Given this list of marker genes UBA7, LRR1, ITIH5, PHB1, SELENOS, RIDA, C11orf58, ITPR2, CTRL, XRN1, EML3, TIMM8B, PARD3 (par-3 family cell polarity regulator), SSBP1, ACAD9, PRPF8, LIPT1, PLXNC1, PRPF40A, USP47, PDE8A, SYNGR2, NAA20, EZH1 (enhancer of zeste 1 polycomb repressive complex 2 subunit), TMEM70, TM9SF4, TMBIM4, COMTD1, MYC, DGLUCY, AGT, IFT27, HIBADH, BSPRY, MED12, TIMM44, CYBA, NFKB2, SPDEF, QPCT, EIF1AX, ADAMTS10, PAWR, TARS2, GRIA3, MRPL45, MED28, NUCKS1, DBT, EPCAM, ST3GAL1, NCAPG2, ZNF202, PALS2, PSMB4, SLC29A3, ARL16, GOLGA4, MAD2L1, TDP2, FAIM, FAM81A, VTA1, TOPBP1, IGF2BP3, M6PR, GYPC, ETFB, USP18 (NCBI Gene Id 11274), RPP25, TBL1X, FBXW9, MAPRE2, ZEB2, ACP6, CEBPZOS, MLLT3, RIPK4, RABL6, REL, MRPS11 (NCBI Gene Id 64963), TWIST1, SEC16B, GSAP, TRAPPC12, PARN, NOL7, BTG1 (NCBI Gene Id 694), CPA2, INTS6, LYSMD2, IDH3A, ACSL5, PTEN, DDX39B, MRPL16, IRAK1, THAP4, MTHFS, NUFIP1, ERAL1 (Era like 12S mitochondrial rRNA chaperone 1), CD27-AS1, FNBP4, EXTL3, UNK, HEATR1, RBCK1, APOOL, MMUT, TM4SF5, SRPK2, NNT, SMC3, DGKE, MLST8, SLFN13, SH3GL3, PTCD2 (pentatricopeptide repeat domain 2), VPS53, ARF3, RNF123 (ring finger protein 123), CD320, SQLE, KMT2A, BFAR, APAF1, DENND2D, STAT6, IL2, SCFD1, TACC2, GBP4, PPCDC, COPRS, ASB3, PATZ1, GTF2H3, FEN1, DALRD3, TAPBP, MPG, TRAF5 (NCBI Gene Id 7188), UBR4, RDH12, CADM1, DAB1, PLAGL1, RGS3, LHX2, CBX4, ELP3, SFT2D1, PJA2, ANAPC1, HMGCS1, FBXL6, COPS7A, MANBA, SH3BGRL, BOD1L1, TCF12, TNFSF8, RAI1, RCCD1 (RCC1 domain containing 1), SDHA, C1QBP, POU2F2, STMP1 (short transmembrane mitochondrial protein 1), C16orf87, RPN2, AAAS, SLC37A1, PIGK, ASB13, FNBP1, C1QC (complement C1q C chain), METTL6, EHD3, DCAF12, COX15, PSME2, CIT, FOXRED1, USP45, TMEM158, PHKB, COX20, PMPCB, RMDN3, SMARCA5 (NCBI Gene Id 8467), SOCS4, HUS1, WDR90, BDH1, DNAJC27, CDKN1A (cyclin dependent kinase inhibitor 1A), GUSB, FANCF, SLC35F5, TFAP4, here is a description of the gene set: studied in species Homo sapiens from publication Ng SY, Yoshida T, Zhang J, Georgopoulos K (PMID 19345118) Regulation of lineage potential and transcriptional priming by Ikaros. New insight is provided into a bivalent regulation of lineage priming in the HSC and its lympho-myeloid restricted progeny the LMPP by the lymphoid lineage-determining factor Ikaros Whereas Ikaros is responsible for the activation of a cascade of lymphoid expression programs and for the establishment of lymphoid potential from the HSC to the LMPP it is also responsible for the repression of stem cell and erythroid genetic programs that are incompatible with further lineage restrictions emanating from the LMPP Human Gene Set: GSE15330_LYMPHOID_MULTIPOTENT_VS_MEGAKARYOCYTE_ERYTHROID_PROGENITOR_UP Genes up-regulated in lymphoid-primed multipotent progenitors versus megakaryo-erythrocyte progenitors.